Given this list of marker genes AKT1, PIK3CA, BAD, ABL1, CRK, CRKL, PIK3CD, CBL, PIK3CB, AKT3, AKT2, here is a description of the gene set: studied in species Homo sapiens Human Gene Set: KEGG_MEDICUS_VARIANT_BCR_ABL_FUSION_KINASE_TO_PI3K_SIGNALING_PATHWAY Pathway Definition from KEGG: BCR-ABL -> (CRKL+CBL+CRK) -> PI3K -> PIP3 -> AKT -| BAD BCR-ABL fusion kinase to PI3K signaling pathway. Pathway ID: N00048. Pathway type: Variant. Pathway class: nt06276 Chronic myeloid leukemia.